Given this list of marker genes Rttn, Crocc, Ccp110, Foxj1, Dzip1, Ulk4, here is a description of the gene set: Mouse Gene Set: GOBP_CILIARY_BASAL_BODY_ORGANIZATION A process that is carried out at the cellular level which results in the assembly, arrangement of constituent parts, or disassembly of a ciliary basal body, a short cylindrical array of microtubules and associated proteins found at the base of a eukaryotic cilium (also called flagellum). species: Mus musculus